The following is a description of a gene set: Catalysis of the reaction: 3'-phosphoadenosine 5'-phosphosulfate + N-acetyl-D-glucosamine = adenosine 3',5'-bisphosphate + N-acetyl-D-glucosamine 6-sulfate. species: Mus musculus Mouse Gene Set: GOMF_N_ACETYLGLUCOSAMINE_6_O_SULFOTRANSFERASE_ACTIVITY, and this is the list of marker genes: Chst5, Chst2, Chst3, Chst4, Chst7, Chst1